Given this list of marker genes LY96, CD14, TLR4, TRIL, HSPD1, here is a description of the gene set: Human Gene Set: GOCC_LIPOPOLYSACCHARIDE_RECEPTOR_COMPLEX species: Homo sapiens A multiprotein complex that consists of at least three proteins, CD14, TLR4, and MD-2, each of which is glycosylated and which functions as a lipopolysaccharide (LPS) receptor that primes the innate immune response against bacterial pathogens.